Given this list of marker genes RPL10L, TPH2, ALDH4A1, RPL35, GCSH, DBT, ASRGL1, RPL36A, RPL19, KYNU, OAZ1, PAPSS2, PSMD2, GLDC, CKB, PSMC1, ACAT1, OCA2, BBOX1, DIO2, ALDH6A1, SERINC5, RPL26, BCKDHA, AGXT, RPS4Y1, CGA, SLC5A5, FAH, AGXT2, TMLHE, GADL1, PSMD3, KYAT1, SCLY, AMD1, AMDHD1, SLC44A1, RPS13, GSR, PSTK, RARS1, BCAT1, TXNRD1, FTCD, PSMD11, SERINC4, TXN2, TPH1, CBS, PSMC4, SLC25A10, SHMT1, TPO, RPS17, CDO1, RPS12, EPRS1, SARS1, RPL32, MCCC2, PHGDH, RPS5, PSMB1, RPS23, RPS2, NQO1, RPL17, INMT, AZIN2, ALDH7A1, RPL35A, GLUL, PSMA4, ADI1, RPS11, RPL37, PSMD6, RPLP2, RPS24, PSMC5, RPS3A (ribosomal protein S3A), DAO, PHYKPL, HPD, GLUD1, MARS1, BHMT2, CKM, ECHS1, AIMP2, DMGDH, GLS2, GATM, PSMD8, OAZ2, MAT1A, IDO2, PIPOX, PYCR1, QARS1, NNMT, RPS4X, PCBD1, ASL (argininosuccinate lyase), RPS9, OTC, SMS, CHDH, GNMT, RPS3, CPS1, GOT2, RPS25, RPL13, BCKDHB, PSMD14, PSMA3, RPL31, PSMB6, BCAT2, ENOPH1, RPS21, MTAP, RPL23, PSMA1, RPL36, RPS4Y2, RPL8, PSMD7, TDO2, RPL21, RPL15, CRYM, ASPG, RPL4 (NCBI Gene Id 6124), CKMT1A, SERINC1, ACMSD (aminocarboxymuconate semialdehyde decarboxylase), AHCY, GCDH, GOT1, ETHE1, KMO, SLC25A21, CKMT2, RPLP0, DLD, RPL38, DBH, HOGA1, RPL41, AGMAT, PSAT1, RPS6, SLC25A44, IARS1, HIBCH, TYRP1, RPL9, MPST, ALDH18A1, LARS1, DHTKD1 (dehydrogenase E1 and transketolase domain containing 1), AIMP1, RPS15, SQOR, NAT8L, RPS27, BHMT, ARG1, SRM, DUOX2, DIO1, SERINC2, RPL36AL, HYKK, CTH, RPL5, RPL14, ASS1, PSMA2, FAU, GAMT, RPL18A, RPL37A, SUOX (NCBI Gene Id 6821), ARG2, HSD17B10, RPS8, RPL10, SECISBP2, MRI1, OGDH, RPL29, DDC, RPL28, ALDH9A1, MTRR, RPSA, APIP, RPL22, PSMD12, RPL27A, GLS, PNMT, RPL30, TH, TYR, GSTZ1, PSMB2, RPS18, ODC1, RPS26, AMT, PYCR3, ACADSB, HNMT, RPL11, IDO1, IVD, RPL24, PSMB5, NAGS, GPT2, RPL3, RPS7, IYD, RPS27A, PSMC6, GRHPR, RPS28, ASPA, SLC25A2, SLC25A15, RPS14, RPL22L1, RPL3L, RPL39L, EEFSEC, PRODH, PAOX, AADAT, RPL7, ACAD8, HGD, SLC36A4, RPL13A, RPL12, PRODH2, SLC6A12, SLC25A13, EEF1E1, KYAT3, SLC25A12, AFMID, RPL6, TAT, RPL7A, TST, DDO, DIO3, PSMA7, PAH, SEPSECS, OAZ3, PSMB3, MTR, PXMP2, FOLH1, CSAD, RPL26L1, SDS, PPM1K, HDC, PSMC2, RPS10, AUH (NCBI Gene Id 549), RPL34, ASNS, SLC45A2, SDSL, SLC3A2, NAALAD2, HAL, PSMB4, DLST, RPS16, RPS15A, RPL10A, ADRM1, SARDH, DARS1, PSMA5, SLC7A5 (NCBI Gene Id 8140), AANAT, RPL23A, RPS29, AASS, SRR, PSMB7, CARNS1, TSTD1, RPS27L, HAAO, SEM1, HAO1, GPT, HIBADH, ASMT, RIMKLB, PAPSS1, PSMC3, SLC6A7, OAT, SEPHS2, RIDA, RPLP1, TSHB, NMRAL1, KGD4, SLC6A8, PYCR2, ADO, SMOX, RPL39, RPS20 (NCBI Gene Id 6224), RPL27, RPS19, GLUD2, PSPH, QDPR, CARNMT1, CKMT1B, SAT1, BCKDK, UBA52, SLC6A11, SERINC3, DUOX1, DCT, MCCC1, IL4I1 (interleukin 4 induced 1), PSMD13, FMO1, KARS1, RIMKLA, RPL18, PSMA6, AZIN1, UROC1 (urocanate hydratase 1), PSMD1, here is a description of the gene set: Human Gene Set: REACTOME_METABOLISM_OF_AMINO_ACIDS_AND_DERIVATIVES species: Homo sapiens Metabolism of amino acids and derivatives